Given this list of marker genes TGM3, SLC24A5, IFT140, GNPTAB, OCA2, NOP10, PAX3, PDE4D, RTEL1, DSTYK, ZFX, TAFAZZIN, PADI3, BLOC1S5, NPM1, PAH, WRAP53 (WD repeat containing antisense to TP53), TYR, TYRP1, MOGS, USB1, DKC1, SLC17A5, AP3B1, UBE3A, MC1R, ACD, LYST, NHP2, DPP9, MYO5A, KITLG, PARN, SLC45A2, SNRPN, UBR1, TYMS, TP63, RMRP, TINF2, TERC, TERT, RAB27A, CTC1, ABCA2, LPAR6, PIGN (NCBI Gene Id 23556), KANSL1, BLOC1S3, MLPH, here is a description of the gene set: Reduced pigmentation of hair diffusely. species: Homo sapiens Human Gene Set: HP_GENERALIZED_HYPOPIGMENTATION_OF_HAIR Generalized hypopigmentation of hair